The following is a description of a gene set: from publication Chen Y, Wang X (PMID 31504780) Human Gene Set: MIR5589_5P studied in species Homo sapiens Genes predicted to be targets of miRBase v22 microRNA hsa-miR-5589-5p in miRDB v6.0 with MirTarget v4 prediction scores > 80 (high confidence targets)., and this is the list of marker genes: IGF2BP3, ORAI2, NXF1, MYH11, BPY2B, ST3GAL1, AGAP1, CWC27, BCL2L11, COL10A1, CDK19, DELE1, TET3, ZBTB39, NBEA, LEF1, BBS1, HEYL, C2CD3, FOXO3, SSR3, ONECUT1, BPY2, BCL11B, POU2F1, EIF2AK1, SGO1, PITPNM2, PIP4K2A, KIF21B, DCUN1D1, TLCD4, KIF24, BPY2C, COL19A1, HECTD1, CSNK1E, CNOT6, GIPC3, RIMS4, S100A12, HDHD2, MAMDC2, NAGA, IRAK3, TSNARE1, HNRNPU, DAZL, FRMD5, MUC1, SH3TC2, APOBEC4, ABR, KRT78, ATCAY, NCAM1, EEIG1, ETV6, VASH2, CDH4, METAP2, EXPH5, SLC24A2, ARID4A, SCAMP4, DHX57, KCNJ6, DGKE, LLPH, L1CAM, NMNAT2, KCNA5, MMP24, ZDHHC3, TENM1, TNS1